The following is a description of a gene set: Human Gene Set: WP_13Q1212_COPY_NUMBER_VARIATION species: Homo sapiens 13q12.12 copy number variation, and this is the list of marker genes: DTNA, TRAF2, ADIPOQ, SGCA, TNFRSF19, RHOA, MIR2276, TRAF5, RTN4, TRAF1, RAC1, SGCB, DMD, SNTB1, LINC00327, RTN4R, SGCG (NCBI Gene Id 6445), TRAF3, SACS (sacsin molecular chaperone), C1QTNF9B, FLNC, SGCD, MAG, MAPK9, ATXN1, CDC42, SNTA1, LINGO1, SSPN, MAPK8, SPATA13, C1QTNF9, DAG1, MIPEP